The following is a description of a gene set: Reactome Pathway: IRF3 mediated activation of type 1 IFN part of: ZBP1(DAI) mediated induction of type I IFNs species: Homo sapiens Interferon regulatory factors (IRF) IRF-3 and IRF-7 are the major modulators of IFN gene expression in response to pathogenic molecules. The relative contribution of IRF3 and IRF7 depends on the signaling pathway that is activated. Type I IFN production in cytosolic DNA-sensing pathway is mediated predominantly by IRF3 and partially by IRF7, since DNA-stimulated IFN-beta and IFN-alpha4 mRNA induction was strongly inhibited in IRF3-deficient mouse embryonic fibroblasts (MEFs), while remained normal (IFN-beta) or reduced (IFN-alpha4) in IRF7-deficient MEFs (Takaoke A et al 2007). IRF3 activation in response to B-DNA stimulation occurs via its co-recruitment with serine/threonine kinase TANK-binding kinase 1 (TBK1) or inducible IkB kinase (IKKi/IKKepsilon) to the C-terminal region of DAI., and this is the list of marker genes: DTX4, ZBP1, TBK1, NLRP4, IRF3